Given this list of marker genes Cst3, Gnai2 (G protein subunit alpha i2), Pdcd5, Cd81, Bcl6, H2-Aa, Nudt9 (NCBI Gene Id 74167), Mt2, Mrpl34, Mtss2, Psmd14, here is a description of the gene set: Cytokines mediate cell-cell communication in the immune system and represent important therapeutic targets. A myriad of studies have highlighted their central role in immune function, yet we lack a global view of the cellular responses of each immune cell type to each cytokine. To address this gap, the authors created the Immune Dictionary, a compendium of single-cell transcriptomic profiles of more than 17 immune cell types in response to each of 86 cytokines (>1,400 cytokine-cell type combinations) in mouse lymph nodes in vivo. A cytokine-centric view of the dictionary revealed that most cytokines induce highly cell-type-specific responses. For example, the inflammatory cytokine interleukin-1β induces distinct gene programmes in almost every cell type. A cell-type-centric view of the dictionary identified more than 66 cytokine-driven cellular polarization states across immune cell types, including previously uncharacterized states such as an interleukin-18-induced polyfunctional natural killer cell state. from publication Cui A, Huang T, Li S, Ma A, Pérez JL, Sander C, Keskin DB, Wu CJ, Fraenkel E, Hacohen N (PMID 38057668) Mouse Gene Set: CUI_MIGDC_SCF_RESPONSE_UP studied in species Mus musculus Genes positively differentially expressed in cell type: MigDC (migratory dendritic cell) upon treatment with cytokine: SCF in mouse lymph nodes in vivo.